Given this list of marker genes Cpsf7, Cpsf6, Rbfox2, Ythdc1, Nudt21, here is a description of the gene set: species: Mus musculus Mouse Gene Set: GOBP_MRNA_ALTERNATIVE_POLYADENYLATION The process of generating multiple mRNA molecules with variable 3'-end length formation from a given pre-mRNA by differential use of cleavage and polyadenylation signals (pA signals).